Given this list of marker genes HMGCS2, HLA-DRB1, ISLR, HLA-DMA, BLVRB, TFF3, CHRNA7, CRYAB, TSPAN1, ACADM, ISL1, LGALS1, ETHE1, EPHX1, SSX1, here is a description of the gene set: Cluster 5: genes with similar expression profiles across follicular thyroid carcinoma (FTC) samples. Human Gene Set: LUI_THYROID_CANCER_CLUSTER_5 The demonstration of the PAX8-PPAR(gamma) fusion oncogene in a subset of follicular thyroid tumors provides a new and promising starting point to dissect the molecular genetic events involved in the development of this tumor form. In the present study, we compared the gene expression profiles of follicular thyroid carcinomas (FTCs) bearing a PAX8-PPAR(gamma) fusion against FTCs that lack this fusion. Using unsupervised clustering and multidimensional scaling analyses, we show that FTCs possessing a PAX8-PPAR(gamma) fusion have a highly uniform and distinct gene expression signature that clearly distinguishes them from FTCs without the fusion. The PAX8-PPAR(gamma)(+) FTCs grouped in a defined cluster, where highly ranked genes were mostly associated with signal transduction, cell growth and translation control. Notably, a large number of ribosomal protein and translation-associated genes were concurrently underexpressed in the FTCs with the fusion. Taken together, our findings further support that follicular carcinomas with a PAX8-PPAR(gamma) rearrangement constitute a distinct biological entity. The current data represent one step to elucidate the molecular pathways in the development of FTCs with the specific PAX8-PPAR(gamma) fusion. species: Homo sapiens from publication Lui WO, Foukakis T, Lidén J, Thoppe SR, Dwight T, Höög A, Zedenius J, Wallin G, Reimers M, Larsson C (PMID 15608688)